Given this list of marker genes Ikbkg, Ufl1, Sting1, Pik3r4, Ubqln4, Slc25a5, Cdk5rap3, Tomm7, Ralb, Gnai3, Atp13a2, Gpsm1, Parl, Irgm2, Htra2, Pink1, Atg5, Fbxl4, Snx18 (NCBI Gene Id 218636), Pip4k2c, Nod1, Tigar, Sptlc2, Ulk1 (unc-51 like kinase 1), Tecpr1, Tlr2, Srebf1, Dele1, Snx30, Wac, Hspb8, Phf23, Sirt1, Lrrk2, Wdr45, Rnf41, Sh3glb1, Atp5if1, Fez1, Atg2a, Bag3, Dnm1l, Zdhhc19, Cln3 (NCBI Gene Id 12752), Tom1, Huwe1, Dcn, Adcy10, Rufy4 (RUN and FYVE domain containing 4), Sesn1, Irgm1, Rnf31, Qsox1, Bnip3, Eif2ak1, Lypla1, Trp53, Wipi1, Gba1, Cers1, Atp6v0a1, Fbxw7, Kat5, Il4, Prkaa2, Trim32, Hdac6, Pafah1b2, Usp36, Epm2a, Lrsam1, Smcr8, Pip4k2b (NCBI Gene Id 84507), Gsk3a, Stub1, Vdac1 (NCBI Gene Id 22333), Pptc7, Snx7, Sesn3, Nrbp2, Npc1, Rab3gap2, Lzts1, Prkn, Ddrgk1, Supt5, Scoc, Larp1, Trim13, Usp30, Snx4, Mul1, Hk2, Ube2a, Ubqln2, Rab12, Hmox1, Rubcn, Tbk1, Mtor, Mapk3, Fbxo7, Elapor1, Pik3c3, Ambra1, Ubqln1, Bnip3l, Poldip2, Vps13c, Rab3gap1, Atg14, Slc25a4, Htt, Wdr24, Tspo, Fez2, Igtp, Fyco1, Ripk2, Fkbp8, Tsc1, Pip4k2a, Sptlc1, C9orf72, Becn1, Map3k7, Adrb2, Sesn2, Csnk2a1, Scfd1, Mtm1, Clec16a, Pim2, Nod2, Moap1, Kdr, Tsc2, Cttn, Hif1a, Sec22b, Nupr1, Tmem39a, Calcoco2, Tbc1d25, Cdc37, Ehmt2, Optn, Atg12, Vps13d, here is a description of the gene set: Mouse Gene Set: GOBP_REGULATION_OF_MACROAUTOPHAGY Any process that modulates the frequency, rate or extent of macroautophagy. species: Mus musculus